The following is a description of a gene set: studied in species Homo sapiens Abnormal light-adapted electroretinogram Human Gene Set: HP_ABNORMAL_LIGHT_ADAPTED_ELECTRORETINOGRAM, and this is the list of marker genes: ATF6, KIF3B, PEX12, RPGR, PDE6C, CNGB3, CACNA1F, OPN1SW, PDE6H, GNAT2, CNGA3